Given this list of marker genes Plekha6, Serpinb1a, Spry1, Nckap5, Hs6st2, Meg3, Pcnx1, H2bc4, Fst, Lrrcc1 (leucine rich repeat and coiled-coil domain containing 1), Gm2a, Cnn1, Optc, Serf1, Klhl30, Fcgrt, Sdf4, Cebpd, Mfap5, Cdhr4, Ly6c1, Cda, Adgrl3, Arhgef3, Gas1, Jarid2, Ablim1, Scn3a, Gjb3, Selenop, Col3a1, Epn3, Synm, Adgrg6, S100a16, Il4ra, Ogn, Ssbp4, Cnp, Prrc2c, Prickle1, Matn2, Or51b17, Cx3cl1, Card10, Dysf, Emilin2, Col6a2, Tmem141, Nsd1, Ecm1, Pnrc1, St3gal5, Echdc2, Adamts4, Dnase2a, Tmem176a, H1f2, Ndrg4, Scara3, Fez1, L3hypdh, Il17rd, Fgf5, Ptp4a3, Rgs4, Tek, Dkk3, Rrad (NCBI Gene Id 56437), Snta1, Arsb, Bmper, Plac9, Auts2, Btg2, Gstm2, Lmo7, BC028528, Ldb3, Egfr, Gas6, Epha4, Rbm26, Dab2, Synpo, 4930428O21Rik, Pdgfb (platelet derived growth factor, B polypeptide), Lgals3bp, Lox, Otor, Prex2, Adamts2, Ifih1, Cacna1g, C1qtnf1, Zfand5, Zfp36l1, Lifr, Lgals9, Tdrd3, Slc7a2, Cast (calpastatin), 1700063H04Rik, Fam43a, Slc16a4, Atp8b4 (ATPase, class I, type 8B, member 4), Rsrp1, Pctp, Clip4, Entrep3, Ahr, Nr4a3, Casp12, Cbr2 (NCBI Gene Id 12409), Fbln1, Kdm7a, S100a13, Fmod, Tlr1, Plxdc2, Actg2, Eny2, Pcid2, Plce1, Col6a1, Ttll7, Trp53inp1, Ly6e, Adamtsl4, Tgfb3, Wnk2, Zfp185, F2rl1, Osr1, Ctsh, Isg15, Pik3ip1, Clmn, Plscr2 (NCBI Gene Id 18828), Rnf150, Tmem154, Btn1a1, Bmp4, Olfml3, Mfap2, Map3k8, Plat, Sppl2a, Tmem176b, Il18, Ltbp2, Tcp11l2, Mapk12, 2900026A02Rik, Bhlhe22, Fbln7, Dram1, Pir, Nfkbiz, Osmr, Afap1l2, Nuak1, Csad, Slc1a3, Gpc4, Mme, Tle2, Pstpip2, Zfp398, Rcbtb2, Ift70b, Tox, Npr3, Hnrnpa3 (NCBI Gene Id 69921), Pcdhb22, Gstt1, Tnfrsf11b, Nt5e, Sting1, Lhx9, Pcdhb21, Tmem30a, Decr1, Pibf1, Plcg2, Arhgap28, Arfgap3, Ifi44, here is a description of the gene set: Up-regualted genes from the set F (Fig. 5a): specific signature shared by cells expressing AF4-MLL alone and those expressing both AF4-MLL and MLL-AF4 fusion proteins. studied in species Mus musculus Mouse Gene Set: GAUSSMANN_MLL_AF4_FUSION_TARGETS_F_UP The reciprocal chromosomal translocation t(4;11) is correlated with infant, childhood, adult and therapy-related high-risk acute leukemia. Here, we investigated the biological effects of MLL.AF4, AF4.MLL or the combination of both reciprocal fusion proteins in a conditional in vitro cell culture model system. Several parameters like cell growth, cell cycling capacity, apoptotic behavior and growth transformation were investigated under physiological and stress conditions. Co-transfected cells displayed the highest resistance against apoptotic triggers, cell cycling capacity and loss-of-contact inhibition. These analyses were complemented by gene expression profiling experiments and specific gene signatures were established for each of the three cell lines. Interestingly, co-transfected cells strongly upregulate the homeobox gene Nanog. In combination with Oct4, the Nanog homeoprotein is steering maintenance of pluripotency and self-renewal in embryonic stem cells. Transcription of Nanog and other stem cell factors, like Oct4 and Bmi1, was verified in biopsy material of t(4;11) patient cells which express both reciprocal t(4;11) fusion genes. In conclusion, the presence of both reciprocal MLL fusion proteins confers biological properties known from t(4;11) leukemia, suggesting that each of the two fusion proteins contribute specific properties and, in combination, also synergistic effects to the leukemic phenotype. from publication Gaussmann A, Wenger T, Eberle I, Bursen A, Bracharz S, Herr I, Dingermann T, Marschalek R (PMID 17130830)